Given this list of marker genes PLG, COL18A1, THSD4, S100A4, LTBP2, ECM1, HCFC1, F2, THBS1, ITIH4, HTRA1, PLOD2, NID2, FBLN2 (NCBI Gene Id 2199), TNN, S100A13, S100A6, TGFB1, CTSB, ADAMTSL1, CD109, ANGPTL4, PLOD3, LGALS3, EFEMP1, SERPINF2, LUM, ANXA2, SERPINB1, LMAN1, BGN, LOXL2, SRPX, P4HA1, SERPINF1, COL4A4, VWA1, P3H3, here is a description of the gene set: studied in species Homo sapiens We employed a proteomic strategy developed to characterize the in-vivo ECM composition of normal tissues and tumors using enrichment of protein extracts for ECM components and subsequent analysis by mass spectrometry. We grew subcutaneous tumors by injection into NOD/SCID/IL2R? mice of A375 human melanoma cells (poorly metastatic) or their highly metastatic derivatives MA2. The tumors were dissected 5 weeks later, and the tumor ECM was enriched and analyzed using mass spectrometry. We define the tumor ECM as the ensemble of ECM proteins and ECM-associated proteins found in two independent samples. A challenging question when studying the tumor microenvironment is to understand the origin of the tumor ECM; that is, whether the tumor ECM is produced and secreted by the tumor cells themselves, by the stromal cells or by both compartments. To address this question, we pursued the analysis of the melanoma xenografts described above, by identifying the origin of each protein. In order to be able to identify without ambiguity the origin of each protein, we required that proteins needed to be detected in two independent samples with at least two species-specific peptides in one of them. Using this strategy, we identified for each tumor type a set of matrisome proteins exclusively secreted by the (human) tumor cells, and another set exclusively secreted by the (murine) stromal cells. This gene set lists the matrisome proteins (based on the criteria mentioned above) secreted by the tumor cells and stromal cells in A375 tumors and not in MA2 tumors. from publication Naba A, Clauser KR, Hoersch S, Liu H, Carr SA, Hynes RO (PMID 22159717) Matrisome proteins exclusively detected in poorly metastatic melanoma human-to-mouse xenografts (A375) in comparison to highly metastatic melanoma human-to-mouse xenografts (A375_MA2). Human Gene Set: NABA_MATRISOME_POORLY_METASTATIC_MELANOMA